The following is a description of a gene set: Mouse Gene Set: TABULA_MURIS_SENIS_MAMMARY_GLAND_LUMINAL_EPITHELIAL_CELL_OF_MAMMARY_GLAND_AGEING studied in species Mus musculus from publication Tabula Muris Consortium (PMID 32669714), and this is the list of marker genes: Bag3, Rp9, Fus, Xbp1 (NCBI Gene Id 52219), Sprr1a, Wsb1, Tmed9, Prrc2a, Ece1, Ewsr1, Mafk, Gstm1, Ralgds, Icam1, Tmem176a, Oaz1, Atp1a1, Arl13b, Trp53inp1, Irx3, Gsto1, Plscr1, C2cd4b, Klc3, Ecm1, Smim14, Cxcl2, Bhlhe40, Id3, Dclk1, Pam, Vasn, Mbd3 (NCBI Gene Id 17192), Abhd16a, Ddx5, Dsp, Ddx3x, Nfkbiz, Ring1, Cebpb, Cd81, Pde4b, Itm2b, Dpep2, Coq10b, Tob1, Rhob, Gem, Junb, Nrtn, Ccnl1, Mia, Cxcl15, Idh2, Gabarapl1, Tmed3, Calm2, Dnaja1, Hspa5, Timp2, Ier5, Cst3, Klf16, Srxn1, Mknk2, Laptm4a, Csrnp1, Crip1, Bsg, Oaz2, Klf2, Arl4c, Ddx6, Krt15, Dcn, Vamp8, Bcl3, Igfbp7, Calr, Kdm6b, Fam110a, Fos, Skil, Arhgdia, Dusp14, Ptms, Krt5, Hspa8, Rela, Perp, Shisa5, Enho, Ifitm2, Tra2b, Prelp, Pbx1, Selenop, Socs2, Snhg9, Mtch1, H2-K1, Ctbp1, Ythdc1, Emc10, H2-Eb1, Hilpda, Hsp90b1, Mcl1, Tnfrsf21, Hnrnpa0, H2-Ab1, Ifitm3, Tmem160, Dusp6, H3f3b (H3.3 histone B), Syne4, Tspan8, Aldh2, Krt6a, Peli1, Tcf7l2, Gatb, Ltf, Drap1 (NCBI Gene Id 66556), Anxa1, Rbm3, Krt17, Dusp18, Rpl13a, Cpe, Pim3, Ybx1, Pdia3, Ube2s, Trib1, Slc66a2, Atp6v1b1, Per1, Ier3, Hp, Egr1, Cnpy2, Gjb4, Creb5, Bcl7c, Nr4a1, H2-Aa, Camk2n1, Tle5, Pdk4, Ppp1r10, Nfib, Klf4, Cdk2ap2, App, Ndel1, Aplp2, Gja1, Apobec3, Cd74, Cd52 (NCBI Gene Id 23833), Hbegf, Btn1a1 (NCBI Gene Id 12231), Scp2, Ell2, Irx5, Cytip, Cx3cl1, Barx2, Ociad1, Mapk3, Gas6, Dhrs3, Atp1b1, Nherf1, Igfbp5, B4galnt1, Ccn1, Tob2, Ccl5, Trps1, Ppp3ca, Serinc3, Fth1, Btg1, Wfdc2, Grn, Mfge8, Jund, Kit, Baiap2, Pdcd4, Cdkn1a, Atf3, Cyb5a, Clca2, Vamp2, Krcc1, Rheb (NCBI Gene Id 19744), Vars1, Zfp36l2, Lmna (NCBI Gene Id 16905), Alcam, Rnf10, Midn, Sik1, Pcf11, Pbxip1, Gnb2, Sf3b2, Nfix, Pdlim3, Map1lc3a, Nop53, Crip2, Tspan17, Brd2, Ssbp4, Klf5, Cxcl14, Fkbp8, Btg2 (BTG anti-proliferation factor 2), Tppp3, Slc7a2, Ftl1, Timp3, Dusp1, Cck, Maff, Epha2, Foxa1, Cfl1 (NCBI Gene Id 12631), Jmjd1c, Ntn1, Nherf2, Erf, Piezo2, Slc29a1, Anp32a, Anapc11, Iffo2, Gprc5a, Bcam, Myh14, Aqp5, Tap2, Cbr2, Ubb, Tmem176b, Ly6d, Emp1 (epithelial membrane protein 1), Dnajb1, Erdr1, H2-D1, Il18r1, Upk3a, Apoe, Cemip2, Fosb, Ltbp1, R3hdml, Ube2b (ubiquitin-conjugating enzyme E2B), Zfp36, Emb, Lamtor4, Fcgbp, Ptma, Cracr2b, Ptov1, Lgals3, Trf, Aoc1, Slc5a5, Stc2, Zc3h12a, Cirbp, Lgals7, Sfpq, Sfn, Slpi, Cd200, Rhoj, Pkp4, Cbx3, Ier2 (NCBI Gene Id 15936), Smagp, Selenow, Lrg1, Plk3, Fosl1 (fos-like antigen 1), Gpx3, Mtarc2, Hint2, Elf3, Hmgb2, Ets2, Pim1, Ccnd1, Tagln2 (transgelin 2), Eif3f, Sertad1, Ido1, Fosl2, Itgb5, Mlph, Pdlim1, Foxp1, Ube2e3, Tsc22d1, Fst, Ogfrl1, Jun, Gsn, Hnrnpm, Usp2, Ly6e, Itm2c, Spr, Tnrc6b, Hnrnpa2b1, Tmem254, Pxdc1, Gm2a, Aldoc, Klf13, Anpep, Sgk1, Ltbp3, Agtr1a, Krt14 (NCBI Gene Id 16664), Ctnnb1, Klf10